Given this list of marker genes NPR3 (NCBI Gene Id 79614), ESR1, CDH3, INS, FGF23, GCH1, here is a description of the gene set: studied in species Homo sapiens Human Gene Set: GOBP_POSITIVE_REGULATION_OF_MONOOXYGENASE_ACTIVITY Any process that activates or increases the activity of a monooxygenase.